Given this list of marker genes Tnfaip3, Ptpn22, Nagk, Slc15a3, Slc15a4, Peli3 (pellino 3), Tlr4, Slc46a2, Hspa1b, Slc15a2, Erbin, Znrf4, here is a description of the gene set: Any process that modulates the frequency, rate, or extent of a nucleotide-binding domain, leucine rich repeat containing receptor signaling pathway (NLR) pathway. Mouse Gene Set: GOBP_REGULATION_OF_NUCLEOTIDE_BINDING_DOMAIN_LEUCINE_RICH_REPEAT_CONTAINING_RECEPTOR_SIGNALING_PATHWAY studied in species Mus musculus